The following is a description of a gene set: from publication Rahman-Roblick R, Hellman U, Becker S, Bader FG, Auer G, Wiman KG, Roblick UJ (PMID 18438429) Human Gene Set: RAHMAN_TP53_TARGETS_PHOSPHORYLATED The p53 tumor suppressor regulates transcription of target genes. We have previously analysed the p53-dependent proteome and identified novel protein targets. Here we have examined p53-dependent phosphorylation using two-dimensional gel electrophoresis and staining with the fluorescent phosphoprotein dye Pro-Q Diamond. We report that p53 induces phosphorylation of a subset of proteins including Nm23, DJ-1, ANXA1 and PrxII. Our identification of p53-dependent phosphorylation of specific target proteins reveals new aspects of the p53-dependent cellular response and suggests that such posttranslational modifications may contribute to p53-mediated tumor suppression. Proteins phosporylated in HCT116 cells (colon cancer) upon p53 activation. species: Homo sapiens, and this is the list of marker genes: HNRNPL, ANXA1 (annexin A1), TPM3, ACTB (NCBI Gene Id 60), PCBP1, MAGOHB, IDH3A, GSTP1, DLD, NME1, PGAM1, CCT6A, VPS29, PHGDH, PPA1, PARK7, PRDX3, RUVBL2, PSMB6, PRDX2